The following is a description of a gene set: Genes predicted to be targets of miRBase v22 microRNA hsa-miR-3925-3p in miRDB v6.0 with MirTarget v4 prediction scores > 80 (high confidence targets). studied in species Homo sapiens from publication Chen Y, Wang X (PMID 31504780) Human Gene Set: MIR3925_3P, and this is the list of marker genes: ACSM5, ZNF730, KCNA4, NUP98, PPP2R3A, CBX5, ZNF273, ATXN7L1, AKTIP, ZNF716, ZNF559, ZNF813, ZNF468, ZNF101, ZNF28, DPH6, ZNF117, ZNF138, ZNF761, ZNF705D, ZNF594, NDUFB5, GPD2, ZNF493, SLC35C2, GNB4, CDH2, ZNF439, ZNF195, ZNF845, RGS16, LYRM9 (NCBI Gene Id 201229), ZNHIT6, ZNF714, SMARCA5, RCHY1, MAP3K3, ZNF718, AAK1, ZNF705EP, ZBTB20, PLCD4, DNAJB11, DAB2, C7orf25, ZNF578, ZNF440 (zinc finger protein 440), IPMK, SLC5A9, ZFP90, MEIS2, ZNF544, ZNF302 (zinc finger protein 302), DUOXA1, ZNF559-ZNF177, ZC2HC1C, ZNF701 (NCBI Gene Id 55762), ZSWIM6, FZD4, RBM46, FAN1, FBXO45, STRADB, SERPINE1 (serpin family E member 1), ALDH1A3, UBXN4, NDST1, ZNF728, SLC25A37, CNOT9, ZNF816-ZNF321P, PRTG, ZNF83, SAR1A, ZNF611, SEMA3A, CCNYL1, CBFB, C22orf46P, MAP4K4, SIRPA, FLAD1, BOC, PTPRB, TACC1, ZNF732, ZNF90, CCDC60, MBNL1, SLC12A8, ZNF626, ZNF808, CNN1, ZNF705A, EPB41L2, PEX13, CDH7, PRR32, ZNF763, SULF1, MARCKS (NCBI Gene Id 4082), NFE2L1, HGF, TENM4, PHKB, ZNF99, ATP2B2, MYRF, ANKRD42, LIMK2, ITGA4, PHTF1, ZNF682, SNW1, AKAP12, GRIA2, SH3TC2, ZNF480, ZSCAN22 (zinc finger and SCAN domain containing 22), ZNF431, ZNF124, ZNF586, RBPMS, PODXL, CABP4, MYO6, CPEB3, OSR1, CELF2, ZNF91, NR1D2, ZBTB10, ZFP1, EFNA3, ZNF490, ZNF765, SLC4A5, ZNF600, ZNF432, ZNF816, ZNF844, ATXN7 (ataxin 7), ZNF708, CCBE1, ZNF208, SF3B1, PLAGL2, TDRD1, HAPLN4, MCHR2, ZNF676, ZNF514, ZNF254 (zinc finger protein 254), ZNF107, ZNF426, APH1B, ZNF773, MOG (myelin oligodendrocyte glycoprotein), AKIRIN1, PKP2, SRGAP1, SLC35F1, ZNF85 (zinc finger protein 85), ZNF675, ZNF888, KLHL29, CDK14